The following is a description of a gene set: The chemical reactions and pathways resulting in the formation of hemoglobin, an oxygen carrying, conjugated protein containing four heme groups and globin. species: Mus musculus Mouse Gene Set: GOBP_HEMOGLOBIN_BIOSYNTHETIC_PROCESS, and this is the list of marker genes: Inha, Epo, Klf4, Snx3, Alas2, Slc6a9, Alas1, Abcb10, Eif2ak1, Ldb1, Inhba, Hif1a, Fech, Slc25a37, Lyn